Given this list of marker genes Apoa1, A2m, Prkacb, Abca1, Prkaca, Bmp1, here is a description of the gene set: This event has been computationally inferred from an event that has been demonstrated in another species.<p>The inference is based on the homology mapping from PANTHER. Briefly, reactions for which all involved PhysicalEntities (in input, output and catalyst) have a mapped orthologue/paralogue (for complexes at least 75% of components must have a mapping) are inferred to the other species. electronically inferred by orthology from the curated human pathway part of: Plasma lipoprotein assembly Reactome Pathway: HDL assembly studied in species Mus musculus